Given this list of marker genes ANAPC10, SCAMP5, SPI1, PAK1, GNL1, HOXC10, USP2, ADAP1, YWHAZ, PNMA3, RNF7, ZNF367, PRR3, RBMS2, OSR1, RIPOR1, PPP2R2A, CCNI, SST, THOC1, CRH, SART3, LDHA (lactate dehydrogenase A), PRELID1, MAFF, HS3ST2, TLNRD1, CBX8, FAM174A, ISCU, CHGB (chromogranin B), ID1, UBE2H, PPM1A, ZNF593, ZNF184 (NCBI Gene Id 7738), DNTTIP1, CHMP1B, PITX2, TRIM39, SREBF2, MMGT1, CHPF, IFT20, PDE7A, CDS1, RUNDC3A, RAB24, ZFAND2B, TIPRL, RPS29, SYNGR3, NEDD1, AREG, TMEM39A, PCK1, NF1, GPR3, EPHA2, ZFYVE27, OGDH, THADA, FOSB, ARG2, SIDT2, VPS37B, HAS1, RBM18, EIF1, SULT4A1, NR4A2, RCAN1, AFF4, CREB3L2, NPTX1, TSC22D3, CDC42, TNFAIP1, TAF2 (NCBI Gene Id 6873), ZC3H10, CDC14B, RUSC1-AS1, TAPT1-AS1, ABCE1, AKIRIN1, ARIH1 (NCBI Gene Id 25820), RAI1 (NCBI Gene Id 6600), SIK1, LTBP1, TH, JUND, SENP2, BABAM2, MAP3K13, MAPK10, FOXD3, WFDC3, LGR5, PKP4, BRAF, PACRGL, ZCCHC17, SNAP25, MIR9-1HG, MCAM, CLDN7, EGR2, GRM3, IKBKB, TSC22D2, ELOVL5, MLF2, DAAM2, TMEM147, RNF166, CLSTN3, DNAJB5, MRGPRF, PLCD3, PLK4, NUP42, TRAF4, FGF6, RBKS, NDUFB2, RPL41 (ribosomal protein L41), AHI1, ATL2, RELB, GLYR1 (glyoxylate reductase 1 homolog), DNAJC27, MXD1, GPBP1, SPAG9, ATG5, ICA1, ITFG2 (integrin alpha FG-GAP repeat containing 2), PNMA6A, TSPAN7, NCDN, JOSD1, FAM131A (family with sequence similarity 131 member A), CDK2AP2, CCDC86, CCDC148, ASPHD1, KICS2, RHOQ, MAOA, SRRM4, PTPRU (protein tyrosine phosphatase receptor type U), HS3ST3A1, PDP1, TAOK2, NUP98, HHIP, CTC1, ATP6V0C, TBC1D32, DDX51 (NCBI Gene Id 317781), TAPT1, IRX6, GTF2A1, KCTD8, DIO2, DCTN1, TRMT10A, RUSC1, UCN, ADCY8 (NCBI Gene Id 114), MBNL2, NOC4L, RNF44, ZNF516-DT, TRIB1, CLDN6, NUBPL, PER1, SUV39H2, MLLT6, DHX36, MRRF, PHACTR3, CMSS1, H4C5, DUSP1, PPP1R15A, C11orf87, SPRED2, ZFAND5, RAB25, RBP5, SCG2, CYSTM1, PAFAH1B1 (platelet activating factor acetylhydrolase 1b regulatory subunit 1), CENPE, PDLIM3, IRF2BPL, PFAS, NEUROD6, KYAT1, MAP1LC3A, SNRNP40, GEM, ALS2, SLC18A2, GPM6B, TPT1 (tumor protein, translationally-controlled 1), CREM, ADNP2, NOL4, LMO4, SLC25A25, USP48, TMEM59L, MYL6, CD2AP, here is a description of the gene set: studied in species Homo sapiens Genes having at least one occurrence of the motif CNNTGACGTMA in the regions spanning 4 kb centered on their transcription starting sites. This matches the CREB1 transcription factor binding site V$CREB_Q4_01 (v7.4 TRANSFAC). Human Gene Set: CREB_Q4_01